The following is a description of a gene set: Human Gene Set: GOBP_POSITIVE_REGULATION_OF_DOPAMINE_SECRETION studied in species Homo sapiens Any process that activates or increases the frequency, rate or extent of the regulated release of dopamine., and this is the list of marker genes: CHRNB2, CXCL12, OPRK1, PINK1, SYT1, GDNF, NPY2R